Given this list of marker genes PCNX1, SIRPA, SLC27A3, RRP7A, SNRNP25, STAR (NCBI Gene Id 6770), FCGR2A, COMMD4, RPL22P22, SNX17, ITGB7, SEL1L3, UPF1, LAMP1, ITGA7, TBCD, DDX23, CD300C (CD300c molecule), PPID, HIC2, IL1RN, NKG7, NUP210, SMPD1, NAGPA, SELPLG, KCTD13, DUSP7, RRBP1, HOXA7, OXLD1, LRRC20, HOXA4, ELF4, TNPO3, SRF, NPY4R, DNAJC1, ACTR2, NDUFC1, IL17RA, HOXA6, NUP50, PLXNB2, CXCR2, KLC1, DHRS7B, ADRB2, CEP63, NLRP3, FADD, IRAK1, SNX1, LGALS1, SLC8B1, LAT2, CCND3, CSF2RA, ALDH3A2, TOR1AIP1, SCPEP1, BID, ATG3, ARHGAP11A, PLPBP (NCBI Gene Id 11212), PYCARD, TFEB, RANGRF, LBHD1, SH3GLB2, FCGR2B, TDRD7, RNASE6, ELMO3, GTSE1, CSTA, RNF19B, MPPE1, ADCY9, IL10RB, SNTB1, LILRA1 (NCBI Gene Id 11024), PPP1R3D, RECK (reversion inducing cysteine rich protein with kazal motifs), NINJ2, IQCE, LTB4R, APOBR, IFNGR2, ABHD2, PSD4, EVI2A, LRFN4, RASSF4, RASSF7, FBXW4, MRPL35, TOR1A, SIPA1, SLC1A4, SAFB2, ARL6IP5, EAF2, ITGB2 (integrin subunit beta 2), DENND2D, DCPS, JMJD1C, C15orf39, CLN3, INSR, MYO1F, CASP1 (caspase 1), TTC1, TANK, S100A6, CCPG1, PIGF, ATP6V0E1, SDHD, HIRIP3, CAT, TRAF3IP3, TIMM23, RNASE3, ATP8B4, CALM1, PSMB8, ZDHHC13, RNASE2CP, UPB1, SFMBT1, MEIS1, SDHB, LPCAT1, CCL23, FLNA, DEXI, SIRPAP1, RBBP8, NAGK, MBNL1, IGF2R, DYNLL1 (dynein light chain LC8-type 1), ABR, AKR7A3, STS, TREX1, SAC3D1, RCAN1, KNG1, RHOT2, M6PR, GNS, RNF167, RAB27A, THAP11, EIF4EBP2, TOLLIP, AK2, NUP62 (nucleoporin 62), ADGB, FUT7 (fucosyltransferase 7), PUDP, RGS14, HOXA9, TBC1D8, SULT2A1, GAS7, OPRL1, CYBA, LAPTM5, PER2, UQCRC1, TOR3A, ITGAX, GOLGA8N, CTSA, CLTCL1, PRDX1, NXT2, MFSD1, IL6R, ENSG00000274253, HSPA1A, SLC43A3, TPP1, AKR7A2, KIAA0930, SLC15A2, MLX, RMND5B, MICAL1, SLA, CDC42EP3, CD302, HOXA10, STAMBP, LYST, ARHGEF3, HTATIP2, NUBP1, MRPL33, UNC119, MVB12B, PECAM1, MALT1, LILRB4 (NCBI Gene Id 11006), PKM, CAPG, RAB4B, MRTFA, RASSF2, DNPH1, GNA12 (NCBI Gene Id 654140), SYNGR2, DPEP2, BATF, CXCR4, IGFBP7, GRN, SERPINB8, LST1, OSBPL8, PBX3, ARHGEF40, CNPY3, MGST2, COX8A, NDUFB8, DMAC2, RRP8, SEPHS2, PCYT1A, GLYR1, SLC9A6, PAGR1, FXYD6, ISG20L2, C11orf21, POLD4, COLGALT1, ADCY7, CYTH4, LCP1, OGG1, PTPN9, DNM2, EHBP1L1, MLLT10, BORCS6, FUCA1, SZRD1, RAC2, SLC36A1, EFHD2, ASPSCR1, NDUFS7, CEBPA, ID2, COA3, PTPN22, MED8 (mediator complex subunit 8), POLR2J, LILRA2, RXRA, UNC50, ELF3, HDAC6, FAM53B, PTK2B, MFSD13A, IRF8, MTMR9, SLC25A11, PTAFR, C1orf54, P4HB, PARL, RBKS, PTPN2, TRIM38, OAZ1, MRPL34, ARHGAP1, TK2, GLG1, TNFRSF10B, RAB29, LMAN2, PITPNA, PRKCD, PILRA, EPHB3, PSMD11, MAGEF1, HOXA5, SPCS1, RNASE2, TOPBP1 (NCBI Gene Id 11073), CD2BP2, SLC22A18, ARHGAP45, FES, SDF4, TXNRD2, IKZF1, ABCA8, FOSL2 (FOS like 2, AP-1 transcription factor subunit), CSPG4, NDUFB3P5, SEC23B, CLTB, SPI1, S100A4, MAPK13, KRI1, FZD2, DACH1, ARPC2, MR1, PLOD1, PLXNC1, PPARD, FRAT2, FCGR1A, CBFB, RBM23, CIAO2B, RPS6KA1, TIGAR, ARPC4, CNIH4, BEGAIN, FAM120A, CEBPG, COMMD8, ARPC1B, ENO1, SYK, CLEC3B, HOXB9, EVI2B (NCBI Gene Id 2124), HEXB, HCLS1, PLD3, SIRPB1, ZNF318, PSEN1, IPCEF1, SPG21, SMCO4, SMIM10L1, ABHD17A, KHNYN, EXOSC4, IRAG2, BMP5, TIMM17B, CHD3, TNFSF13, RAB6A, ADARB1, PPIF, SLC16A3, GRB2, TADA3, HNRNPU, IGFLR1, LILRB2, TRIM44, B4GALT1, IQSEC1, CAND2, NIPBL, KRT10, ABCA7 (ATP binding cassette subfamily A member 7), CCR1, TGFA, HOMER3, PAQR4, TGOLN2, TRAPPC10, PMM1, C1RL, SNX10, here is a description of the gene set: species: Homo sapiens The 'MLL signature 1': genes up-regulated in pediatric AML (acute myeloid leukemia) with rearranged MLL compared to all AML cases with the intact gene. Somatic mutations in nucleophosmin (NPM1) occur in approximately 35% of adult acute myeloid leukemia (AML). To assess the frequency of NPM1 mutations in pediatric AML, we sequenced NPM1 in the diagnostic blasts from 93 pediatric AML patients. Six cases harbored NPM1 mutations, with each case lacking common cytogenetic abnormalities. To explore the phenotype of the AMLs with NPM1 mutations, gene expression profiles were obtained using Affymetrix U133A microarrays. NPM1 mutations were associated with increased expression of multiple homeobox genes including HOXA9, A10, B2, B6 and MEIS1. As dysregulated homeobox gene expression is also a feature of MLL-rearranged leukemia, the gene expression signatures of NPM1-mutated and MLL-rearranged leukemias were compared. Significant differences were identified between these leukemia subtypes including the expression of different HOX genes, with NPM1-mutated AML showing higher levels of expression of HOXB2, B3, B6 and D4. These results confirm recent reports of perturbed HOX expression in NPM1-mutated adult AML, and provide the first evidence that the NPM1-mutated signature is distinct from MLL-rearranged AML. These findings suggest that mutated NPM1 leads to dysregulated HOX expression via a different mechanism than MLL rearrangement. Human Gene Set: MULLIGHAN_MLL_SIGNATURE_1_UP from publication Mullighan CG, Kennedy A, Zhou X, Radtke I, Phillips LA, Shurtleff SA, Downing JR (PMID 17597811)